The following is a description of a gene set: This event has been computationally inferred from an event that has been demonstrated in another species.<p>The inference is based on the homology mapping from PANTHER. Briefly, reactions for which all involved PhysicalEntities (in input, output and catalyst) have a mapped orthologue/paralogue (for complexes at least 75% of components must have a mapping) are inferred to the other species. Reactome Pathway: Adrenoceptors species: Mus musculus electronically inferred by orthology from the curated human pathway part of: Amine ligand-binding receptors, and this is the list of marker genes: Adrb1, Adrb3, Adra2c (NCBI Gene Id 11553), Adra1a, Adra2a, Adra2b